Given this list of marker genes Nme4, Nme6, Nme1, Nme7, Cad, Nme5, Nme2, Nme3, here is a description of the gene set: studied in species Mus musculus Mouse Gene Set: GOBP_UTP_BIOSYNTHETIC_PROCESS The chemical reactions and pathways resulting in the formation of UTP, uridine (5'-)triphosphate.